The following is a description of a gene set: Human Gene Set: HP_SHORT_LONG_BONE Short long bone One or more abnormally short long bone. studied in species Homo sapiens, and this is the list of marker genes: GNPNAT1, SNRPB, POLR3A, IFT80, STX5, IFT172, B3GLCT, RFWD3, PAM16, LZTFL1, TCTN3, FERMT1, IQCE, TMEM67, FBN1, EXTL3, TBX4, CDC42BPB, PCYT1A, PRKAR1A, STX16, POC1A, HOXD13, FGFR3, MTHFS, SLC35B2, RUNX2, AMMECR1, FANCB, ATR, CREB3L1, OBSL1, PEX7, CHN1, SMAD4, KIAA0753, SF3B4, FBXL3, FGF10, EVC2, GHR, EIF4A3, TBX3, DLK1, BRCA1, LAMA5, ASXL2, CCN2 (cellular communication network factor 2), BMP2, SALL1, ROBO1, XYLT1, BRCA2, PEX5, FLNB, SMARCA2, INPPL1, CHD7, PTH1R, MET, FANCF, PIK3CD, DNA2, PCNT, TTC21B, FANCM, CEP120, SLC31A1, LRP4, HEPHL1, GPX4 (glutathione peroxidase 4), PHYH, AFF3 (NCBI Gene Id 3899), ZIC3, BRIP1, RNU4ATAC, GNAS-AS1, DCHS1 (NCBI Gene Id 8642), PPOX, MATN3, NADSYN1, POR, CCNQ, FANCA, NEK9, EXT2, RAD51C, EXT1, MAP3K7, RSPRY1, LONP1, TAF6, RAD51, CANT1 (NCBI Gene Id 619513), ADAMTSL2, AMER1, COL9A3, GLB1, IFT52, IFT140, ALG9, PRMT7, AGPS, ERCC4, HYLS1, MYSM1, EVC (EvC ciliary complex subunit 1), GSC, SRCAP, TRPV6, WNT5A, SALL4, CLDN16, PORCN, NHS, SLX4, DONSON, BMPR1B, FLNA, NOG, CUL7, PIGS, BGN, MAD2L2, PTHLH, MEGF8, SMOC1, TBX15, SMC1A, ESCO2, SHH, EP300, DNMT3A, TAPT1, RTL1, KNSTRN, RPL26, EBF3, LTBP3, XRCC2, NIPBL, FIG4, DHODH, BRD4, GDF5, SCUBE3, RAB33B, WDR35, SUCLG1, COL10A1, RMRP, PDE4D, FANCE, ANAPC1, RAB23, SRY, CAMK2A, WNT7A, GNPAT, FAT4, EZH2, B2M, FANCL, NPR2, TBX5 (NCBI Gene Id 6910), RBM10, INTU, VPS13B, ZSWIM6, IHH (NCBI Gene Id 50819), LMBR1, CPLANE1, ZNF407, TONSL, FANCG, CHSY1, PIGT, HHAT, SLC10A7, FANCI, GNAS, DYNC2I1, RPL13, HDAC4, UBAP2L (NCBI Gene Id 9898), PRKG2, ATP7A, APC, IL6ST, FGF16, RAD21, DVL1, GPC6, TCF4, PDE3A (phosphodiesterase 3A), VPS35L, MAFB, FGFR2, RBM8A, SMC3, RPS6KA3, RAB3GAP2, B3GALT6, TWIST2, TNFRSF11B, DDRGK1 (DDRGK domain containing 1), ACVR1, IFT122, SH3PXD2B, SERPINH1, COMP, SOX9, SLC35A2, SETBP1, PUF60, FN1, ROR2, CCDC8, PALB2, PTCH1, SVBP, COG1, DYNC2LI1, MEG3, UBE2T, IFT81, RAB34, SLC39A13, FGFR1, TRIP11, NEPRO, DYNC2H1, P3H1, PLCB3, TGDS, AFF4, DYNC2I2, BHLHA9, SLC26A2, C1GALT1C1, FZD2, SCARF2, ALG12, COG4, EXOC6B, RIPK4, TNFRSF11A, LIFR, COL11A2, NEK1, COL11A1, COL2A1, GNPTAB, RBPJ, SIL1, RPS19, SHOX, COL9A1, FANCC, KCNJ2, SLC35D1, ERI1, TRPS1, DDR2, IARS2, ITPR1, HINT1, CD96, DYM, GLI3, TRPV4, BPNT2, HSPG2, HOXA13 (homeobox A13), LBR, HDAC8, CWC27, RECQL4, JAG1, FANCD2, CHST3